Given this list of marker genes Lrrtm2, Afdn, Grin2d, Syt7, Sh3gl1, Bsn, Syt9, Slc30a3, Adcy8, Sh3gl2, P2rx3, Mal2, Fmr1, Grin3b, Tnr, Snap47, Nectin3, Pdyn, Sumo2, Epha7, Gabra6, Gper1, Anks1b, Grin2b, Cdh9, Bace1, Ephb2, Ctnnd1, C1ql3, Slc6a9, C9orf72, Cacng2, Ppp3r1, Rapgef4, Stxbp5, Lnx1, Rnf19a, Ywhaz, Gnai2 (G protein subunit alpha i2), Syt12, Calca, Grik4, Ptprd, Dtnbp1, Grik2, Napepld, Grin1, Efnb3, Akap7, Calb1, Unc13b, C1ql2, Capzb, Bdnf, Shank2, Slc39a3, Ctnna2, Nectin1, Syt1, Rogdi, Prkar1b, Synpr (NCBI Gene Id 72003), Vti1a (vesicle transport through interaction with t-SNAREs 1A), Slc16a7, Adcy1, Grik5, here is a description of the gene set: studied in species Mus musculus One of the giant synapses that form between the mossy fiber axons of dentate gyrus granule cells and the large complex spines of CA3 pyramidal cells. It consists of a giant bouton known as the mossy fiber expansion, synapsed to the complex, multiheaded spine (thorny excresence) of a CA3 pyramidal cell. Mouse Gene Set: GOCC_HIPPOCAMPAL_MOSSY_FIBER_TO_CA3_SYNAPSE